Given this list of marker genes Fgf6, Frs2 (fibroblast growth factor receptor substrate 2), Spry2, Cbl, Fgf8, Kl, Fgf17, Rps27a, Fgf22, Fgf4, Fgf10, Fgf2, Fgf20, Mapk3, Fgf5, Fgf23, Fgfr1, Fgf1, Ubb, Grb2, here is a description of the gene set: Reactome Pathway: Negative regulation of FGFR1 signaling electronically inferred by orthology from the curated human pathway This event has been computationally inferred from an event that has been demonstrated in another species.<p>The inference is based on the homology mapping from PANTHER. Briefly, reactions for which all involved PhysicalEntities (in input, output and catalyst) have a mapped orthologue/paralogue (for complexes at least 75% of components must have a mapping) are inferred to the other species. part of: Signaling by FGFR1 species: Mus musculus